Given this list of marker genes VIM, CNTN6, CCN2, SYT2, GPD1L, ADGRV1, MDK, HILPDA, HOATZ, VSTM2L, COL2A1, RCOR2, PRC1, CENPF, KIF11, MMRN1, CDK1, TTR, CIMAP3, ARMC3, CDKN3, PLEKHA5, FOXJ1, PRADC1, BMP7, LGI1, ZFP36L2, CHN2, ANXA5, MELK, CKS1B, CDON, NES, CHRDL1, CFAP210, FAM13A, TFF3, PDGFC, SDC4, NCAPG, CENPU, RPS14, OTX2-AS1, NECTIN3, CCND1, FZD1, CYTL1, FANCI (NCBI Gene Id 751608), AJUBA (NCBI Gene Id 84962), ACVR1, MSI1, DMRTA2, BMP1, NUSAP1, ZFP36L1, CDCA5, HES1, AQP4, ZMAT4, CDO1, IGFBP2, KITLG, L3HYPDH, LIPG, RAI14, IQGAP2, SPAG17, PLK1, AURKB, DSG2, SULF1, ARX, SRF, MAML2, SOX2, DEPDC1B, CMTM8, TMEM132C, TMEM47, FAT3, SERTM1, SLF1, CDCA3, MCM3 (minichromosome maintenance complex component 3), TSPAN11, ENO1, DDIT4, DYNLT5, CTHRC1, EFNA5, CCN1, CENPE, PPP1R3C, RCN1 (NCBI Gene Id 5954), CRISPLD1, FOXA1, MCM5, PDLIM5, OTX2, ABCA8 (NCBI Gene Id 10351), MMP11, MEST, APOA1, GTSE1, ARL4A, TOX, ITGB8, CCDC8 (NCBI Gene Id 83987), SFRP2, NOX4, DDC, DNAH7, CELSR1, ITGB3BP, C6orf118, NRCAM, FREM2, PDE3A, GASK1B, TMEM98, MAP6, ADSS2, EN2, CFAP126, ITGA6, RPA3 (replication protein A3), TCIM, MIR3652 (microRNA 3652), CIBAR2, SDC2, PBK, WNT1, UCP2, BRCA1, H2BC9, ACTL6A, CERKL, ARSJ, HMGA2, GTF2F2, SLIT2 (NCBI Gene Id 9353), HYDIN, SALL1, SCN7A, CKAP2L, PBXIP1, SERPINF1, PLOD2, COL27A1, FAT1, IGF2BP1, NCAPH, CYYR1, GBX2, CLXN, CENPQ, CAP2, RFC3, MAD2L1, HJURP, RAB13, CEMIP2, MIR99AHG, CENPW, BUB1, CNTN4, MAGT1, RPL18, PTGR1, TOP2A, RIPPLY3, DSC2, IGDCC3, RPL23A, SKA3, CRYZ, ARHGEF28, RSPH4A (radial spoke head component 4A), FOXA2 (forkhead box A2), TACC3, NPY, CFAP44, BIRC5, KLHDC8B, LMX1A, UHRF1, LMX1B, TOX3, STON1, BDH2, ALCAM, TRAM2, TPBG, FOXP2, IRS1, PLCL1, MLF1 (myeloid leukemia factor 1), MAGOH, SPAG6, STAR, CCNB2, CFAP144, HMMR, AGAP12P, TBL1X, ZNF497, BMP4, DIPK2A, SPC25, PLP1, WEE1, KIF2A, BUB1B, CNPY1 (NCBI Gene Id 285888), RPGR, TRIM59, JADE1 (jade family PHD finger 1), SHROOM3, NXPH1, KCNG1, KIF15, MND1, HK2, SLC7A11, PON2, ENSG00000255647, GRM8, FNDC3B, CEP152, EFEMP2, DCC, RBP1, RFX4, SP5, HMGA1, NCAPG2, FRMD3 (FERM domain containing 3), AGO1, NEK11, JAM3, RNASEH2A, TTK, RBM24, KLHL32, FNDC1, PAM, EFCC1, TRABD2B, CD47, PPIL6, MNS1, WNT5A, CORIN, H3C2, PDZRN3, MMP2, RSPO3, TROAP, GINS2, PHGDH, MID1, SALL4, MCM2, SLC39A8, ARHGEF26, FOXM1, ARHGAP24, PTPRO, TWIST1, C1orf226 (chromosome 1 open reading frame 226), CDC25A, RPL13AP5, IFT88, PROM1 (prominin 1), HMGB2, PLTP, RERG, GNG5, TMSB15A, TYMS, PTX3, NUF2, ENPP2, PDE11A, ARAP2, KCNMA1, FZD2, JAM2 (junctional adhesion molecule 2), GULP1, RBMS1, H4C12, CHEK1, CRB2, ARHGAP5-AS1, PLXDC2, RSPH9, LRP2, ERF, CDCA8, GDPD2, SH3RF1, RALGPS2, TXLNB, HEATR5A, P4HA1, YAP1, RPS19, here is a description of the gene set: Cell types are named using anatomical and functional mnemonics prefixed by 'm' or'h' to indicate mouse and human respectively: OMTN, oculomotor and trochlear nucleus; Sert, serotonergic; NbM, medial neuroblast; NbDA, neuroblast dopaminergic; DA0-2, dopaminergic neurons; RN, red nucleus; Gaba1-2, GABAergic neurons; mNbL1-2, lateral neuroblasts; NbML1-5, mediolateral neuroblasts; NProg, neuronal progenitor; Prog, progenitor medial floorplate (FPM), lateral floorplate (FPL), midline (M), basal plate (BP); Rgl1-3, radial glia-like cells; Mgl, microglia; Endo, endothelial cells; Peric, pericytes; Epend, ependymal; OPC, oligodendrocyte precursor cells. species: Homo sapiens Human Gene Set: MANNO_MIDBRAIN_NEUROTYPES_HPROGM from publication La Manno G, Gyllborg D, Codeluppi S, Nishimura K, Salto C, Zeisel A, Borm LE, Stott SRW, Toledo EM, Villaescusa JC, Lönnerberg P, Ryge J, Barker RA, Arenas E, Linnarsson S (PMID 27716510)